Given this list of marker genes TMEM30A, ABCA2, TMEM30B, ABCA3, ATP10A, ATP11C, ATP8B1, ATP11B, ATP11A, ATP10B, ATP8B4, ABCA4, MFSD2A, ATP9B, ABCB4, RFT1, ATP8A2, ATP8B2, ABCA7, ATP10D, ABCG1 (NCBI Gene Id 9619), ATP8A1, ABCB1, ABCA12, ABCA1, ATP9A, ATP8B3, here is a description of the gene set: studied in species Homo sapiens Human Gene Set: GOMF_ATPASE_COUPLED_INTRAMEMBRANE_LIPID_TRANSPORTER_ACTIVITY Catalysis of the movement of lipids from one membrane leaflet to the other, driven by ATP hydrolysis. This includes flippases and floppases.